The following is a description of a gene set: CD4 T cell help is critical for both the generation and maintenance of germinal centers, and T follicular helper (TFH) cells are the CD4 T cell subset required for this process. SAP (SH2D1A) expression in CD4 T cells is essential for germinal center development. However, SAP-deficient mice have only a moderate defect in TFH differentiation as defined by common TFH surface markers. CXCR5+ TFH cells are found within the germinal center as well as along the boundary regions of T/B cell zones. Here we show that germinal center associated T cells (GC TFH) can be identified by their co-expression of CXCR5 and the GL7 epitope, allowing for phenotypic and functional analysis of TFH and GC TFH populations. Here we show GC TFH are a functionally discrete subset of further polarized TFH cells, with enhanced B cell help capacity and a specialized ability to produce IL-4 in a TH2-independent manner. Strikingly, SAP-deficient mice have an absence of the GC TFH subset and SAP- TFH are defective in IL-4 and IL-21 production. We further demonstrate that SLAM (Slamf1, CD150), a surface receptor that utilizes SAP signaling, is specifically required for IL-4 production by GC TFH. GC TFH cells require IL-4 and IL-21 production for optimal help to B cells. These data illustrate complexities of SAP-dependent SLAM family receptor signaling, revealing a prominent role for SLAM receptor ligation in IL-4 production by germinal center CD4 T cells but not in TFH and GC TFH differentiation. Human Gene Set: GSE21380_TFH_VS_GERMINAL_CENTER_TFH_CD4_TCELL_UP from publication Yusuf I, Kageyama R, Monticelli L, Johnston RJ, Ditoro D, Hansen K, Barnett B, Crotty S (PMID 20525889) studied in species Homo sapiens Genes up-regulated in CD4 Tfh (T follicular helper) cells: Tfh versus Tfh from germinal center., and this is the list of marker genes: ICAM2, TENM4, SYNE4, SASH1, EGFR, STXBP1, GNAI2 (NCBI Gene Id 2771), CCNYL1, IKZF2, MDGA1, RBMS2, DAG1, HOXA5, DMRT1, LCN2, SAT2, ZNRF4, GABRA4, FKBP9, ANKRD1, FAH, TMEM144, BHLHA15, CCL21 (NCBI Gene Id 6366), AP2M1, TJP2, PITPNM1, SELENOM, DNAJC30, SLC35C1, PPP1R14D, C1R, MRPL52, CD4, NDUFAB1, ASZ1, ST3GAL1 (ST3 beta-galactoside alpha-2,3-sialyltransferase 1), RAB38, ECE1, CFB, PIGN, PKD2, MAMDC2 (NCBI Gene Id 256691), DNAJB2, NDUFB6, MPDZ, RNF181, SPEM1, CPNE8, SLC12A7, BSPRY, TAT, NFE2, DTX3, CASKIN2, MAMSTR, RASD1, ORM1, PIK3AP1, SRC, BPIFB3, UBTD1, PAK4, C11orf52, ZFPM2, CTTN, INPP1, ZCCHC3, ZAP70, PTPN12, ITGA2B, TMEM119, SLC48A1, PNPLA6, PLA2G5, ESAM, NMNAT3, PHLDB2, TAGLN2, TAGLN, NOL6, TFF2, NBDY, DAPK1, TMEM40, IMPDH2, PLCG2, SLC35E4 (solute carrier family 35 member E4), CDK18, RAB11FIP5, LRP1, NR0B2, SPNS2, STX3, F2R, LDLRAP1, AMBP, CHCHD10, PPP1R15A, BCAS1, TRIP6, ARMCX1, SLC66A2, CSGALNACT1, GRHL3, GJB3, ARFGAP2, FCHSD1 (NCBI Gene Id 89848), GFAP, APLP2, RNF112, PLXNB1 (NCBI Gene Id 5364), CISD3, SGTA, BDH1, CELF5, PIANP, GLI1, TSLP, MPL, NAALADL2, FCGR2B, RPL24, CA5B, HID1, CFAP107, UFSP1, COL5A3, NXNL2, C12orf75, TMEM120A, VPS53, DIRAS2, PIP5K1C, PCARE, IL1A (interleukin 1 alpha), CORT, NPHS1, P2RX1, SNX33, SMAGP, SOCS3, FGD5, CITED1, SFRP1, CABP5, APOE, HOXB5, MGST2, ZNF628, AJUBA, PAK6, MYLK, FAM114A1, RNF185, FADS1, TBKBP1, MOCOS, GJB1, CCDC120, POLM, TIE1, KRT1, TNK2, ANXA11, UPK2, DMD, RHBDL2, RBMS3, MAP3K14, NUAK1, MMP2, CLEC11A, PROZ, HSD17B14, KRT18, CYB561, BAIAP2, KIRREL1, SHROOM4, MPZL1, CAPN15, ZFP37, ACTN1, GSTM1, NOP10, TBC1D8, UBE2V1, TNIK, ALOXE3, URM1, RGS7BP, ADGRE5, CD274, GFOD2, ARMC3, VASH1, THSD7A, FERD3L (NCBI Gene Id 222894), CUEDC1